Given this list of marker genes Tent5c, Tent4b, Papolg, Tent4a, Tent2, Papolb, Papola, Tent5a, Tent5b, Mtpap, Tut1, Tent5d, here is a description of the gene set: species: Mus musculus Catalysis of the reaction: ATP + RNA(n) = diphosphate + RNA(n)-3'-adenine ribonucleotide. The primer may be an RNA or DNA fragment, or oligo(A) bearing a 3'-OH terminal group. Mouse Gene Set: GOMF_POLY_A_RNA_POLYMERASE_ACTIVITY